The following is a description of a gene set: Mouse Gene Set: GOCC_NUCLEAR_PORE_OUTER_RING species: Mus musculus A subcomplex of the nuclear pore complex (NPC) that forms the outer rings of the core scaffold, a lattice-like structure that gives the NPC its shape and strength. In S. cerevisiae, the two outer rings each contain multiple copies of the following proteins: Nup133p, Nup120p, Nup145Cp, Nup85p, Nup84p, Seh1p, and Sec13p. In vertebrates, the two outer rings each contain multiple copies of the following proteins: Nup133, Nup160, Nup96, Nup75, Nup107, Seh1, Sec13, Nup43, Nup37, and ALADIN. Components are arranged in 8-fold symmetrical 'spokes' around the central transport channel. A single 'spoke', can be isolated and is sometimes referred to as the Nup84 complex (S. cerevisiae) or the Nup107-160 complex (vertebrates)., and this is the list of marker genes: Nup43, Sec13, Nup85, Ahctf1, Nup133, Nup98, Nup37 (NCBI Gene Id 72714), Nup107, Nup160, Seh1l